Given this list of marker genes DRD3, CHRNA4, HTR4, CHRNE, ACKR1, PTGER1, EDNRA, ADGRB3 (adhesion G protein-coupled receptor B3), PDGFRL, OPCML, C5AR1, GPR17, ADCYAP1R1, RGR, CXCR5, F2RL2, S1PR2, LTB4R, OR10H3, NPY1R, CHRM1, CXCR4, S1PR4, ACKR2, CHRNB4, CMKLR2, HTR3A, GHRHR, OPRK1, PTGER3, GPR65, GALR3, HTR2C, GP1BB (glycoprotein Ib platelet subunit beta), P2RY14, PTGFR, ADGRE1, CCR8, PTH1R, OXTR, P2RY10, HTR6, NPR3, HCAR3, NPY2R (NCBI Gene Id 4887), TACR3, ADGRL1, GPR3, CHRNB1, CRCP, CNR1 (cannabinoid receptor 1), ADRB2, AVPR1B, RRH, LPAR1, CCKBR (cholecystokinin B receptor), CCR2, CCR1, LANCL1, CCL13, CCR3, GP1BA, GPR39, HCRTR1, PRPH2, FPR3, ADRA2A, ADRA1B (adrenoceptor alpha 1B), BDKRB2, CXCR6, EDNRB, HRH1, GRPR, ADRA2B, CALCRL, GPR182, GPR75, PTGER2, HTR7, ADRB1, C3AR1, LPAR6, ADORA2A, PRB4, HCRTR2, FZD2 (frizzled class receptor 2), OR2F1, CX3CR1, HTR2B, NPY, GNAT2 (G protein subunit alpha transducin 2), AGTR1, FPR1, AVPR1A, PTH2R, VIPR1, GPR171, CCR5, GPR183, SSTR2, FPR2, P2RY6, here is a description of the gene set: species: Homo sapiens Human Gene Set: MODULE_146 Genes in the cancer module 146.